Given this list of marker genes Vdr, Hdac4, Nr3c1, Thrb, Nr1i2 (nuclear receptor subfamily 1, group I, member 2), Ar, Pias4, Sumo1, Esr1, Nr1h4, Nr5a1, Rara, here is a description of the gene set: studied in species Mus musculus Reactome Pathway: SUMOylation of intracellular receptors This event has been computationally inferred from an event that has been demonstrated in another species.<p>The inference is based on the homology mapping from PANTHER. Briefly, reactions for which all involved PhysicalEntities (in input, output and catalyst) have a mapped orthologue/paralogue (for complexes at least 75% of components must have a mapping) are inferred to the other species. part of: SUMO E3 ligases SUMOylate target proteins electronically inferred by orthology from the curated human pathway